Given this list of marker genes CXCL10 (C-X-C motif chemokine ligand 10), CXCL11, CXCL13, CXCL9, PF4, here is a description of the gene set: Binding to a CXCR3 chemokine receptor. Human Gene Set: GOMF_CXCR3_CHEMOKINE_RECEPTOR_BINDING species: Homo sapiens